The following is a description of a gene set: Human Gene Set: GOBP_REGULATION_OF_NEURON_APOPTOTIC_PROCESS Any process that modulates the occurrence or rate of cell death by apoptotic process in neurons. species: Homo sapiens, and this is the list of marker genes: DRAXIN, MAP3K11, SLC25A27, EGLN2, GPRASP3, ADCY10, ISL1, GATA3, BCL2L1, FOXB1, MIR15B, RETREG1, PYCR1, CHL1, GRID2, SNX6, CCND1, BCL2L11 (NCBI Gene Id 150819), CFLAR, FBXW7, GSK3A, SNCB (synuclein beta), CLCF1, PRNP, HTR2A, FBXO7, EGR1, CASP6, NTRK1, SNCA, PINK1, TMBIM1, AMBRA1, JUN, ERBB3, NONO, GRIK2, VEGFB, NRBP2, BRAF, NR3C1, CASP8, SOD2, CASP3, HIF1A, MFSD8, FIS1, UBB, CNTF, MAP2K4, MIR200A (NCBI Gene Id 406983), NF1, TRIM2, PRODH, NUPR1, CASP2, FGF20, KDM2B, ATM, GRN, EPHA7, CASP14, SIX1, AARS1, AXL, ASCL1, JAK2, MIR195, MAG (myelin associated glycoprotein), MAP2K7, CCL3, ST8SIA2, ATP7A, TP53 (tumor protein p53), TFAP2B, TGFB3, WNT1, FCGR2B, FOXO3, NAE1, TFAP2D, MDK, ALKBH1, PITX3, PLXND1, XRCC2, MSH2, HRK, RAPSN, CASP10, SET, CLN3, NTF4, KCNB1, PPARGC1A, NRP1, CASP7, IL6ST, OXR1, FASLG, NGF, PRKCG, KRAS, NPPC, NTF3, CLU, RASA1, SYNGAP1 (synaptic Ras GTPase activating protein 1), ITGA1, TRAF7, FAIM2, NOS1, TFAP2A, KDR, DNAJC5, ATF4, UNC5B, TGFB2, SRPK2, FPR2, DKK1, HRAS, LONRF2, POU4F1, CASP9, RIPK1, MIR132, ATP13A2, ZPR1, MECP2, PIK3CA, SOD1 (superoxide dismutase 1), HYOU1, NSMF, MT3, BBS10, MAP3K12, CASP12, GSK3B, NR4A3, MEF2C, FZD1, EPHA4, HDAC3, SLC1A1, SARM1, MCL1, TMBIM4, DLX1, BTG2, CASP5, MMP2, CASP4, CORO1A (coronin 1A), EN2, VSTM2L, EGLN1, BACE1, FZD9, KIF14, DDIT3, RHOA, EN1, PCDHGC4, PCDHGC3, ADORA2A, ABL1, PRKN, PHB1, SIRT1 (NCBI Gene Id 23411), TYRO3, TOX3, CNTFR, ADNP, ARMCX5-GPRASP2, STXBP1, ANGPT1, IL10, BOK, BDNF, CDK5R1, PARP1, APP, CD2AP, NDNF, LCN2, AKT1, BCL2, AIMP2, CEBPB, NTRK2, LIG4 (DNA ligase 4), UCN, MIR212, CX3CR1, GRINA, GBE1, GDF5, TP73 (tumor protein p73), MTNR1B, UCP2, HSPG2, AGAP2, LGMN, CX3CL1, PSEN1, PCDHGC5, CLN8, SIX4, CDK5, BAX, GRM4, G6PD, CBLC (Cbl proto-oncogene C), GDNF, ROCK1, ADAM8, CITED1, PARK7, AKT1S1, VPS54, NAIP, GFRAL, GCLM (NCBI Gene Id 2730), SIGMAR1, MIR181C, NFATC4, GBA1, FYN, PRKCI, THAP11, MYB, TREM2, STAMBP, NMNAT1, AIFM1, BARHL1, RAD21, EGLN3, MIR98, CCL2, HIPK2, F2R, PTK2B, PCSK9, PLA2G3, BBC3, PPT1, FGF2, TNF, NR4A2, TERT, NEFL, IL27RA, NES, HTRA2, CTNNB1, WFS1, GCLC, FGF8, CRLF1, CPEB4, SEMA3E, PTPRZ1